Given this list of marker genes Nr5a2, Pde12 (NCBI Gene Id 211948), Zc3hav1, Ifnb1, Isg15, Ppid, Top2b, Top2a, Ddb1, Shfl, Ppia (peptidylprolyl isomerase A), Inpp5k, Gm11772, Tnf (NCBI Gene Id 21926), Pkn2, Plscr1, Oas1f, N4bp1, Mavs, Ifitm1, Ifnl3, Ifi208, Rad23a, Rnasel, Oas1e, Mir378a, Fam111a, Tarbp2, Tmem39a, D1Pas1, Zfp809, Mir24-2, Hacd3, Trim38, Mir24-1, Ifih1, Ltf, Oas1a, Srpk1, Rsad2, Eif2ak2, Oas3, Ppih, Bst2, Gbp7, Bcl2, Ifi206, Isg20, Stau1, Ifi203-ps, Oas2, Notch1, Ppihl, Larp1, Oas1b, Ilf3, Oas1d, Prox1, Ifi213, Oasl1, Ifi207, Ifitm2, Mir93, Ifi214, Setdb1, Srpk2, Hmga2, Mx2, Vapb, Ifitm3, Oasl2, Oas1g, Morc2b, Trim28, Ddx3x, Trim6, Morc2a, Ddx5, Oas1c, Aicda, Znfx1, Banf1, Ifi209, Fkbp6, Mphosph8, Ifitm6, Ifitm7, Ppie, Adar, Ccl5, Ifi203, Cnot7, Apobec3, Slpi, Tasor, Dicer1, Adarb1, Mndal, Oas1h, here is a description of the gene set: studied in species Mus musculus Any process that modulates the frequency, rate or extent of viral genome replication. Mouse Gene Set: GOBP_REGULATION_OF_VIRAL_GENOME_REPLICATION